The following is a description of a gene set: studied in species Homo sapiens The regulated exocytosis of secretory granules containing preformed mediators such as histamine and serotonin by a platelet. Human Gene Set: GOBP_PLATELET_DEGRANULATION, and this is the list of marker genes: FCER1G, STXBP1, SYK, PLEK, ABCC4, LYN, P2RX1, TPH1